The following is a description of a gene set: Human Gene Set: GOBP_POSITIVE_REGULATION_OF_INTERLEUKIN_23_PRODUCTION Any process that activates or increases the frequency, rate, or extent of interleukin-23 production. species: Homo sapiens, and this is the list of marker genes: IL17RA, IL17A, CLEC7A, CSF2, PLCG2, MYD88, IFNG